The following is a description of a gene set: Fusion of intracellular membrane-bounded vesicles with the pre-synaptic membrane of the neuronal cell resulting in release of neurotransmitter into the synaptic cleft. studied in species Mus musculus Mouse Gene Set: GOBP_SYNAPTIC_VESICLE_EXOCYTOSIS, and this is the list of marker genes: Rimbp2, Rims3, Gpr151, Lrrk2, Dtnbp1, Slc4a8 (NCBI Gene Id 59033), Htr1d, Ppfia3, Snap29, Rph3al, Syt4, Fmr1, Rph3a, Rap1b, P2ry2, Dnm1l, Stx1a, Syt12, Unc13a, Efr3a, Rab3a, Scrib, Cacna1a, Cplx1, Fbxl20, Unc13c, Cplx4, Npy, Dvl1, Rab5a, Stxbp2, P2rx1, Sv2a, Ctbp2, Cacna1e, Snapin, Brsk1, Sv2c, P2ry4, Trim9, Wnt7a, Unc13b, Sv2b, Syt2, Syt7, Cspg5, Stx4a, Cplx3, Rims1, P2ry1, Prkcb, Doc2g, Pfn2, Grik5, Napa, Stxbp1, Syt10, Cacna1d, Pclo, Prkcg, Syde1, Stxbp3, Syn1, Syt5, P2rx2, Tprg1l, Ppfia2, Otof, Syt8, Syt11, Stxbp5, Snap23 (NCBI Gene Id 98773), Atp2a2, Snca, Napb, Snap47, Cadps2, Stx19, Npy1r, Doc2b, Kcnh1, Stx11, Vamp1 (NCBI Gene Id 78668), Rims4, Git1, Htr1b, Vps18, Stx2, Rap1a, Vamp2, Doc2a, Septin5, P2rx7, Cplx2, Syp, Braf, Osbpl2, Rims2, Syt9, Rab3gap1, Psen1, Syngr3, Synj1, Cacna1b, Ncs1, Syt1, Stx1b, Prepl, Syt13, Cacnb4, Erc2, Stxbp5l, Bcl2l1, Erc1, Prkaca, Prrt2, Snap25, Git2, Sptbn2, Prkca, Camk2a, Fbxo45, Nlgn1, Cadps, Cask